The following is a description of a gene set: species: Mus musculus Mouse Gene Set: GOBP_PHOTOTRANSDUCTION The sequence of reactions within a cell required to convert absorbed photons into a molecular signal., and this is the list of marker genes: Pde6c, Aipl1, Cngb1, Rrh, Pde6d, Gnat2, Gnat1, Asic2, Rho, Gpr88 (G-protein coupled receptor 88), Lrit1, Grk1, Ttr, Rbp4, Slc24a4, Gnat3, Pnpla2, Opn4, Opn1sw, Cabp4, Gnb1, Opn3, Opn5, Cds2, Guca1b, Gpr52, Rcvrn, Arrb1, Opn1mw, Guca1a, Rgr, Pcp2, Gngt1